The following is a description of a gene set: species: Mus musculus Mouse Gene Set: GOCC_PROTEIN_COMPLEX_INVOLVED_IN_CELL_CELL_ADHESION Any protein complex that is capable of carrying out some part of the process of cell-cell adhesion., and this is the list of marker genes: Nlgn1, Nrxn1, Lgals1, Lgals2, Izumo1, Glipr1l1